The following is a description of a gene set: Enables the transmembrane transfer of a calcium ion by a voltage-gated channel. A voltage-gated channel is a channel whose open state is dependent on the voltage across the membrane in which it is embedded. Mouse Gene Set: GOMF_VOLTAGE_GATED_CALCIUM_CHANNEL_ACTIVITY species: Mus musculus, and this is the list of marker genes: Cacna1d, Calhm1, Ncs1, Cacna1h, Cacna1g, Cachd1, Oprm1 (NCBI Gene Id 18390), Cacnb2, Cacnb1, Cacna2d4, Cacng7, Rimbp2, Tmc1, Cacna1e, Catsper4, Cacna2d1, Catsper1, Htr1b, Itgav, Ryr1 (NCBI Gene Id 20190), Pkd2, Cacna1b, Cacna1c, Cacng5, Cacng8 (calcium channel, voltage-dependent, gamma subunit 8), Tmc2, Cacng2, Catsper2, Cacng4, Cacnb4, Cacna1s, Cacna1f, Cacng3, Cacna1i, Cacnb3, Trpa1, Grm7, Tspoap1, Cacna2d3, Tpcn2, Cacna1a, Cacng1 (calcium channel, voltage-dependent, gamma subunit 1), Catsper3, Cacna2d2